Given this list of marker genes Reep3 (NCBI Gene Id 28193), Prpf4b, Tnrc6a, Ywhab, Dnajc10, Nnt, Mtif3, Cd84, Armcx1, here is a description of the gene set: Mouse Gene Set: MIR_6968_3P from publication Chen Y, Wang X (PMID 31504780) studied in species Mus musculus Genes predicted to be targets of miRBase v22 microRNA mmu_miR_6968_3p in miRDB v6.0 with MirTarget v4 prediction scores > 80 (high confidence targets).